The following is a description of a gene set: studied in species Homo sapiens Cardiac amyloidosis Extracellular deposition in cardiac tissue of a proteinaceous material that, when stained with Congo red, demonstrates apple-green birefringence under polarized light and that has a distinct color when stained with sulfated Alcian blue. Viewed with electron microscopy, the amyloid deposits are seen to be composed of a beta-sheet fibrillar material. These nonbranching fibrils have a diameter of 7.5 to 10 nm and are the result of protein misfolding. Human Gene Set: HP_CARDIAC_AMYLOIDOSIS, and this is the list of marker genes: TTR (transthyretin), APOA1, SAA1, GSN, B2M